The following is a description of a gene set: Any process that modulates the frequency, rate or extent of response to wounding. species: Mus musculus Mouse Gene Set: GOBP_REGULATION_OF_RESPONSE_TO_WOUNDING, and this is the list of marker genes: Hmgb1, Cd9, Kng1, Apoh, Scarf1, F12, Reg3a, F2, Igf1r, Inpp5f, Ntrk3, Hif1a, Slc12a2, Plau, Adamts18, Foxc2, Atp7a, Ptger4, Ephb2, Thbd, Rtn4rl1, Kank1, Ubash3b, Tmem97, Ptn, F11, Anxa5, Gp5, Cldn19, Omg, Fgg (NCBI Gene Id 99571), Serpine2, Ceacam1, Sh2b3 (SH2B adaptor protein 3), Pdgfb, Tmx1, Cd24a, Tmprss6, Pros1, Cd109, Itgb1, Il33, Dsg2, Fgb, Pten (NCBI Gene Id 70161), Insl3, Neo1, Mylk, Mtor (NCBI Gene Id 80612), Fkbp1b, Rtca, Arfgef1, Ajap1, Tpsab1, Stk24, Mdk, Apoe, Duox2, Rgma, Hrg, Extl3, Il17a, F2r, Epha4 (NCBI Gene Id 98323), Prdx2, Ptprf, Ptk2, Klkb1, Adra2a, Wnt4, Crk, Serpinf2, Fgf2, Psg23, Cadm4, Tnf (tumor necrosis factor), Myoz1, Hbegf (heparin-binding EGF-like growth factor), Map2k2, Cldn13, Ptpn6, C1qtnf1, Tafa5, F7, Cxcr4, Cers2, Vwf, Smad3, Ptprs, Pum2, Clec7a, Git1, Reg3g, Tfpi, Emilin2, Ccl2, Hpse, Cpb2, Muc16, Fermt2, Smoc2, Kremen1, Phldb2, Tnr (tenascin R), Mmrn1, Dmtn, Alox12, Map2k1, Tnfrsf12a, Ndel1, Ano6, Cask, Vtn, Tspan8, Rreb1, Serpinc1, Ddr2, Cav1, Klf4, Clasp1, Emilin1, Duox1, Plaur (NCBI Gene Id 18793), Anxa2, Plat, Serpine1, Cd36, Prkg1, Serping1, Clasp2, Vegfb, Fga, Stat3, S100a9, Anxa1, Proc, Eppk1, Wfdc1, St3gal4, Adtrp, F2rl1 (NCBI Gene Id 14063), Gp1ba, Lrp1, Adam17, Il10, Plg, Braf, Thbs1, Cntf, Cldn3, Pdgfra, Hras, Lrig2, Vkorc1, Pdgfa, Srsf6, Prkcd, Alox5, Xbp1, Kng2, Actg1 (actin, gamma, cytoplasmic 1), Rtn4r, Cldn1, Flna, Xylt1, Ccn4, Grn (NCBI Gene Id 14824), Vil1, Prkce, Tbxa2r, Siglecg, Nfe2l2, D130043K22Rik, Nrg1, Fermt1, Enpp4, Foxa2, Cldn4